Given this list of marker genes PNKP, BTD, VPS16, CARS2, ERCC6, UQCRC1, FDXR, SCN1B, GRM7, COG2, DNM1, SLC25A22, SIK1, PMPCA, DCDC2, TIAM1, WARS2, NEUROD2, RARS1, TBCD, ATP13A2, COQ2, CASK, SCN2A, TRIM8 (NCBI Gene Id 81603), PSAP (NCBI Gene Id 83009), ARX, PRKAR1B, DHCR7, CTSF, GRIN2A, HSD17B10, KARS1, HTRA1, ATP6AP2, FARS2, DMXL2, PIGQ, TMEM67, GRIN1, MED17, TBP, CDKL5, COG5, GNAO1, GALC (galactosylceramidase), SLC32A1, MOCS2, FMR1, TBC1D24, DNM1L, PIGP, KCNA1, GLB1, here is a description of the gene set: Human Gene Set: HP_DIFFUSE_CEREBRAL_ATROPHY Diffuse cerebral atrophy species: Homo sapiens Diffuse unlocalised atrophy affecting the cerebrum.